Given this list of marker genes SPRTN, UFD1, POLE2, UBC, POLE3, POLK, RFC4, UBB, POLE4, VCP, RCHY1, RFC5, POLE, POLI, RFC3, REV1, RFC2, POLD4, NPLOC4 (NPL4 homolog, ubiquitin recognition factor), TRIM25, POLD3, RPA1, PCNA, REV3L, POLH, UBA52, RPA2, MAD2L2, POLD1, USP10 (NCBI Gene Id 9100), RPS27A, POLD2, UBE2L6, ISG15, UBA7, USP43, RFC1, PCLAF, RPA3, here is a description of the gene set: part of: DNA Damage Bypass Reactome Pathway: Translesion synthesis by Y family DNA polymerases bypasses lesions on DNA template Ubiquitous environmental and endogenous genotoxic agents cause DNA lesions that can interfere with normal DNA metabolism including DNA replication, eventually resulting in mutations that lead to carcinogenesis and/or cell death. Cells possess repair mechanisms like nucleotide excision and base excision repair pathways to maintain the integrity of the genome. However, some types of lesions are repaired very inefficiently and others may not be recognized and repaired before the lesion-containing DNA undergoes DNA replication. To prevent acute cell death through arrested DNA replication at unrepaired lesions, cells have a mechanism, referred to as translesion synthesis (TLS), which allows DNA synthesis to proceed past lesions. TLS depends on the Y family of DNA polymerases. studied in species Homo sapiens